The following is a description of a gene set: Mouse Gene Set: GOBP_DNA_REPAIR_COMPLEX_ASSEMBLY The aggregation, arrangement and bonding together of a set of components to form a DNA repair complex. species: Mus musculus, and this is the list of marker genes: Mcmdc2 (NCBI Gene Id 240697), Rad51, Dmc1, Rad52, Rad51c